Given this list of marker genes Fgl2, Dll3, Mycn, Ror2, Thoc5 (THO complex 5), Ifng, Gpr55, Smad7, Tnfsf9, Mapk8, Egr3, Il36b, Prxl2a, Dbn1, Zbtb7a, Pten, Acvr2a, Rag1, Gsk3b, Lilrb4a, Cdkl5, Kras, Erbb2, Ell3, Id2, Rbfox2, Tsc2, Il10, Cul4a, Nrg1, Sos1, Pilrb1, Tnr, Ednrb, Stk11, Xlr3b, Sox8 (NCBI Gene Id 20681), Tyrobp, Rest, Hook3, Rapgef2, Mfn1, Srrt, Tlr2, Mup20, Nfkbid (NCBI Gene Id 243910), Kcnk18, Tmem131l, Plxnd1, Id4, Cul7, Rnf10, Cx3cl1, Map2k1, Myf6, Ctr9, Akap5, Adcyap1, Ppp3ca, Sos2, Bmpr2, F2, Dcx, Stat5b, Serpine2, Il18, Amigo1, Cd28, Dbnl, S1pr3, Vegfc, Nkx2-2os, Esrra, Clcn2, Hoxb3, Ambra1, Draxin, Ntf3 (NCBI Gene Id 30909), Ptk2, Mir219a-2, Fbn1, Cav3, Id1, Tbx6, Jun, Mir150 (NCBI Gene Id 387168), Sema3f, Tmem64, Rtn4r, Tnfsf11, Brd7, Il20, Khdc3, Btn2a2, Mafb, Spint1, Flt3l, Adgra2, Prune1, Hap1, Kalrn, Ankle1, Ctdsp1, Abcc8, Hif1a, Sema4f, Zbtb7b, Dicer1, Ada, Isg15, Eif6, Tlx2, Tiam2, Cd24a, Zfp608, Ephb2, Ntrk3, Zfp683, Tmem176a, E2f1, Rgs14, Kifap3, Cers2, Mir124a-3, Tsc22d1, Ptprd, Cib1, Chd7, Dlg4 (NCBI Gene Id 13385), Mir124a-1, Map2k2, Tnfrsf12a, Hsf1, Gfap, Nme2, Npr2, Hes5, Cdk5, Ist1, Adam7 (a disintegrin and metallopeptidase domain 7), Cebpa, Fancd2, Ing5, Rela, Inpp5d, Gsx2, Islr2, Cdh4, Sorl1, Plag1, Mir132, Cit, Trim11, Il21, Sh2b3, Tfe3, Bhlhe41, Cysltr1, Nfam1, Kit, Ptk2b, Rac3, Mdk, Reck, Trf, Dusp10, Lrp1, Ferd3l, Neurl1a, Traf6, Mpl, Gper1, Ache, Dct, Mmp14, Flt1, Spinkl, Actl6b, Caprin1 (cell cycle associated protein 1), S100a10, Map1b, Daam2, Ppargc1b, Trpc5, Mysm1, Limk1, Robo2, Gabpa, Dnm1l, Pou4f1, Pla2g3, Fbxo7, Zeb2 (NCBI Gene Id 319891), Gja1, Socs5, Actr3, Cxcl12, Twf2, Jak3, Fes, Cyfip1 (NCBI Gene Id 29878), Grip2, Plcb1, Hlx, Ccl9, Il17d, Ccl5, Leo1, Axl, Hes2, Nkx2-2, Il6, Dynlt1b, Fshb, Carmil2, Slamf8, Prkca (NCBI Gene Id 18750), Prmt5, Yap1, Dtx1, Lrp6, Xrcc4, Clec2i, Vnn1, Il2, Tlr9, Tcp11x2, Pafah1b1, Ss18l1, Dcstamp, Faim, Nckap1l, Brd4, Wdr62, Ntrk2, Hoxa9, Prox1, Hey2, Nr2e1, Shtn1 (NCBI Gene Id 71653), Ctla4, Cebpb, Snap91, Hoxa5, Cyld, Rhoa, Cdh1, Tox, Tmem178, Cd101, Sema3a, Il17a, Il12b, Camk2b, Rock2, Mir133b, Obsl1, Irgm1, Gpr37l1, Vsx2, Skic8, Slitrk1, Ppp2r3c, Pparg, Skil, Nedd9, Gpr137 (G protein-coupled receptor 137), Gdi1, Bmp7, Smarcb1, Rpl4, Il4ra, Malt1, Rnf112, Tmprss12, Loxl3, Nrdc, Gpr171, Stau2, D130043K22Rik, Pbrm1, Meis1, Zfp488, Rab7b, Brpf3 (NCBI Gene Id 268936), Mir219a-1, Pde3a, Trem2, Il7r, Myog (NCBI Gene Id 17928), Baiap2, Kdm1a, Brd2, Cnot4, L3mbtl1, Opa1, Rarg, Sox12, Lpar3, Slc46a2, Rc3h1, Bdnf, Hmgb2, Xrcc5, Pias3, Sox10, Wnt7b, Brd1, Cask, Glul, Tspo, Hoxb8, Nrp1, Tcim, Foxp1, Duxbl1, Ttpa, Rbp1, Cdkl3, Dhx36, Egr2, Rfx3, Ptn, Sema7a, Arid1a, Pglyrp3 (NCBI Gene Id 242100), Spart, Il15ra, Adcy10, Slit1, Adnp, Vax1, H2-Aa, Hdac4, Arid2, Gimap5, Lilrb4b, Ctnnb1, Wnt3a, Mitf (NCBI Gene Id 17342), Ttc3, Actl6a, Apcs, Syt4, Anxa2, Sart1, Hmgb3, Nog, Fbxw7, Pglyrp2 (peptidoglycan recognition protein 2), Plxnc1, Dll4, Add1, Brinp1, Kif14, Klhl25, Itgam, Appl2, Zfp335, Tcta (NCBI Gene Id 97549), Bhlhb9, Lox, Iapp, Lgals9, Syk, Mef2c, Disc1, C1qc, Ltf, Lrp8, Pnp, Cdkn2b, Hes6, Prelid1, Picalm (phosphatidylinositol binding clathrin assembly protein), Nox1, Shank3, Runx3, Fstl4, Abl1, Fanca, Bcl2, Actb (NCBI Gene Id 11476), Rorc, Fos, Il4, Gorasp1, Snai2, Nefl, Fzd3, Cd83, Rflna, Prdm16, Gli3, Kdm4a, Nptn, Rps19, Heyl (NCBI Gene Id 56198), Rac1, Cdc73, Gata2 (GATA binding protein 2), Rnf6, Pira12, Aspm, Foxg1, Cdk6, Atf5, Il4i1, Nme1, Clec2d, Bin1, Sirt2, Zbtb46, Wee2, Grn, Bcl11a, Itgb1, Kat6a, Sfrp1, Ngf, Cftr, Dip2b (NCBI Gene Id 239667), Zfp365, Vcl, Epha4, Mag (NCBI Gene Id 17136), Wnt2, Lig4, Dlx2, Ldlr, Xrcc2, Lrp2 (NCBI Gene Id 99378), Rgma, Gfi1b, Nf2, Lrrk2, Otp, Snw1, Hmga2, Ins1, Mturn, Myb, Il7, Ankrd54, Fmr1, Thy1, Etv5, Rheb, Siglec15 (sialic acid binding Ig-like lectin 15), Rnf41, Foxj1, Fezf2, Stat5a, Nkx6-1, Smurf1, Irf1, Gata1, Aspa, Ascl1, Tnfsf4, Zap70, F11r, Ccl11, Thpo, Akap11, Shh, Megf8, Fbxo31, Lgals1, Il6st, Zeb1, Slc9b2, Cd1d1, Caprin2, Hdac9, Zfp36, Hoxd11, Nrarp, Trim46, Idh2, Dmrta2, Crabp2, Pde5a, Oprm1, Hmgb1, Pira1, Pak1, Clec4g, Fstl3, Ccr2, Faxdc2, Rhoh, Hcls1, Ifrd1, Ndel1, Acvr1b, Clock, Qki, Cd44, Twist2, Vegfa, Ikzf1, Map6, Setd1a, Ptpn6, Lck (NCBI Gene Id 16818), Arhgef2, B2m, Drosha, Spi1, Gata3, Evi2b (ecotropic viral integration site 2b), Lyn, Atg7, Zbtb1, Bcl6, Ywhah, Bnc1, Olig2, Fn1, Ins2, Adam8, Ccr7, Rc3h2, Bmpr1a, Evi2, Itpka, Ptprc, Shb, Tgfbr2, Plxna3, Ryk, Prmt1, Tjp2, Vim, Ski, Ihh, Pf4, Nap1l1, Atxn1, Tmem176b, Cyp26b1, Lif, Ddrgk1, Trak2, Pitx3, Hdac6, Klf10, Skint1, Nf1, Prdm1, Rassf2, Hoxa11, Bmp2, Helt, Mbp, Mme, Golga4, Prkdc, Zfp36l1, Kctd11, Pck1, Ulk2, Acin1, Tnfrsf11a, H2-Ea, Sema6c, Notch2, Spen, Il1rapl1, Foxo3, Cldn5, Nkx6-2, Il12a, Myf5, H2-M3 (histocompatibility 2, M region locus 3), Foxn1, Ccr1l1, Tnfrsf1a, Nfkbia, Dab1, Il1rl2, Tnfrsf1b, Anapc2, Mir23a, Creb1, Dock7, Srf, Kat5, Pcid2, Pthlh, Tle6, Socs1, Jade2, Prkch, Ankrd27, Cartpt, Trim32, Zcchc24, Sema4d, Ilk (integrin linked kinase), Myod1, Rnd2, Mecp2, Lmo2, Cd27, Fxr2, Tcf7, Zc3h12a, Clcf1, Tert, Xbp1, Tbx21, Flt3, Mir124a-2, Rab21, Tescl, Rbm15, Sema5a, Smarcd1 (SWI/SNF related, matrix associated, actin dependent regulator of chromatin, subfamily d, member 1), Kat6b, Clec12a, Cd40lg, Pglyrp1, Cdon, Ezh2, Wnt7a, Eeig1, Hdac1, Cysltr2, Cux2, Ntn1, Lrrc17, Grb14 (growth factor receptor bound protein 14), Gas6, Mettl3, Per2, Meaf6, Pik3r1, Slc30a1, Frzb, Nppc, Stat3, Casz1, Wnt3, Prkci, Asxl2, Gimap3, Smarca2, Serpinf1 (serine (or cysteine) peptidase inhibitor, clade F, member 1), Csf1r (NCBI Gene Id 12978), Drd3, Syngap1, Xrcc6, Gjc2, Clptm1 (NCBI Gene Id 56457), Tespa1, Trim58, P4htm, Hdac5, Fas, Sox11, Mapt (microtubule-associated protein tau), Fbxo22 (NCBI Gene Id 78764), Fgf13 (NCBI Gene Id 14168), Pglyrp4, Bmal1, Nfkbiz, Trib1, Ldb1, Sh3glb1, Tal1 (T cell acute lymphocytic leukemia 1), H2-Oa, Star, Drd2, Ripk1, Rock1, Prdx2, Prl2c2, Ikbkb, Cd69, Bmyc, Sox2, Trpc6, Zdhhc21, Eif2b2, Pak3, Runx1, Jag1, Ulk1, Efna5, Egfr, Rptor, Ptprs, Phf10, Lingo1, Lin28a (lin-28 homolog A), Bex1, Sgk1, Arhgap32, Zfpm1, Psen1, Tob2, Parp6, Ikzf3, Bhlhe40, Dag1, Cux1, Rassf10, Axin2, Smo, Ets1, Prtg, Afdn, Klf13, Marcks, Sema6d, Zmiz1, Il2ra, Myo5b, Mir301, Grip1, Clec2g, Ripk2, Ninj1, Kitl, Tmem98, Mir212, Hes1 (hes family bHLH transcription factor 1), Dnajb11, Lhx2, Sox4, Med1, Nr1d1, Atp11c, Arrb2, Lmod3, Macf1, Slc4a2, Il1a, Lef1, Rara, Smarcc1, Tgm2, Ccl19, Ypel4, Cldn18, Il23a, Csf1, Aurka, Ager, Casp8, Zfyve27, Fadd, Cfl1, Cx3cr1, Anxa1, Wls (NCBI Gene Id 99763), Ret, Eif4g2, Actn3, Dlk1, Actr2, Cd46, Ascl2, Smap1, Mt3, Clec7a, S1pr2, Abcb1a, Braf, Itpkb, Car2, Scin, Tcp11, Ptpn2, Stat1, Meis2, Gpr137b, Hoxa7 (homeobox A7), Bag1, Il15, Ccl20, Il27, Gpr68, Synj1, Ppp1cc, Foxp3, Lrp4, Numbl, Hey1, Igf1, Notch1, Robo1, Mir223, Fgf2, Cdkn2a, Pcm1, Reln, Sh3rf1, Enpp2 (ectonucleotide pyrophosphatase/phosphodiesterase 2), Cyp51, Gh, Crtam, Adipoq, Grm5, Cdh5, Fbxw8, Hltf (NCBI Gene Id 99533), Il3, Rag2, Fzd4, Bmp4, Il5, H2-DMa, Trak1, Tnfaip6, Fxn, Hsp90aa1, Ceacam1 (NCBI Gene Id 26365), Ndfip1, Ifnb1 (interferon beta 1, fibroblast), Il2rg, Mbd1, Hes7, Trpv1, Tgfb1, Hdac2, Hspa1b, Nlrp3, Proc, Apc, Eef2k, Hspb1, Senp1, Plxnb3, Tesc, Efnb3, Sash3, Dll1, Hax1, Rufy3, Abcb10, Ccl21b (C-C motif chemokine ligand 21B (leucine)), Inhba, Ccr5, Smarce1, Trp53, Prpf19, Golga2, Paf1, Apoe, Mapk14, Ocstamp, Pik3r6, Adrm1, Lag3, Tnfrsf11b, Kdr, Tenm4, Cip2a, Dpysl5, Sema3g, Ptprf (NCBI Gene Id 19268), Fgfr3, Lta, Pithd1, Metrn, Nodal, Dscam, Rtn4, Tnik, Rasgrp1, Fam210b, Hspa9, Tnf, L1cam, Ccr1, Ccr6, Hes3, Smarcd3, Fezf1, Ep300, Card11, Tnfsf18, Csf3, Pias2, Trpv2, Itgb3, Csf3r, Slc7a5, Wnt10b, Tbc1d24, Ufl1, Ythdf2, Zfp609, Nin, Il1b, Vsir, Nfatc4, Man2a1, Ptprz1, Atoh1, Mfn2, Ctnna1, Fshr, Stk25, Sox13, Shox2, Il34, Plxnb2, Rcor1, Prkcz, Dixdc1, Rflnb (NCBI Gene Id 76566), Met, Cxcr4, Rb1, Btg2, Smarca4, Cd4, Zc3h8, Myrf, Map3k13, Myc, Ubash3b, Pax6, Plxnb1, Mir326, Nkap, Pou4f2, Slit2, Ace, Bad, Ap3b1, Smarcc2, Chodl, Ap3d1, Map2, Ccl3, Kat7, Smarcd2, Zfp35, Numb, Ptpra, Kat2a, Cbfb, Zfp36l2, Dlx1, Dleu2, Mtor, Tiam1, Epha7, Cd74, Il33, Ctf2, Wnt5a, Inpp4b, Erfe, Trp73, Gnas, Nos1, Smad4, Fxr1, Ctla2a, Ctnnbip1, Arhgap4, Mir125a, here is a description of the gene set: Mouse Gene Set: GOBP_REGULATION_OF_CELL_DEVELOPMENT studied in species Mus musculus Any process that modulates the rate, frequency or extent of the progression of the cell over time, from its formation to the mature structure. Cell development does not include the steps involved in committing a cell to a specific fate.